Given this list of marker genes SPINK5, TRIM55, RSPRY1, CALCRL, MAP3K13, TGIF2, CDIN1, DENND4A, PLEKHA6, DYNC1I1, JPH1, FERRY3, EYA2, CREBZF, CYB5R4, R3HDM2, TRAF7, SORT1, NEDD4, HOXB2, EPHB2, RPS6KB1, APOBEC2, ZNF593, TMED10, SLC25A12, MGAT4C, CTCF, ZBTB43, TAF5, LBX1, RPL4, GAB2, PRRG4, UBR5, CAPN6 (calpain 6), PPP1R3D, UNC13B, ARL4C, RAB1A, COL7A1, HOXD10, EPHA3, STK3, IMPDH2, PNOC, CLSTN2 (NCBI Gene Id 64084), DAP3, LCOR, IRS1, PSME3, EYA1, UQCRC2, LRRTM1, SLC16A6, CACNB3, GOLGA6L9, DYNLRB2, PUM3, CDKN2B, SPRED1, FITM1, INPPL1, CDKN2C, KCNH2 (potassium voltage-gated channel subfamily H member 2), TNIP3, ST7L, ACVR1, GOLGA8A, DNAJB5 (NCBI Gene Id 25822), DCAF17, ANKS1B, SEMA7A, ADCY10, PARP16, NIPBL, APBA1, RBX1, HNF1B, GOLPH3L, ITCH, FNBP1L, IRX4, GPC4, TNFRSF19 (TNF receptor superfamily member 19), CDH10, DYSF, CEP57, ABLIM1, ABTB2, C12orf42, CTNNA3, GOLGA6L2, MXI1, EDC4, ALDOC, WDR49, MYF6, GTF2F2, SOST, DNM3, H1-0, PSME3IP1, GOLGA6A, TGFBR1, NXPH4, GPHN (gephyrin), LHX1, TGIF1, LNPK, TSHZ2, NMNAT2, TMEM125, TNS2, SELPLG, BMP1, NRGN, SESN1, NR4A3, SLC4A10, ADGRB3, ZC3H18, IKZF5, APOO, WWC1 (NCBI Gene Id 23286), PCBP4, POU3F3, NLK, UNC79, PBRM1 (NCBI Gene Id 55292), UBE3D, RAD51AP1, HOXA2, PDGFRA, CAB39, GLRA1, TUBB2B, MOSMO, ACVR2A, SCUBE3, ELAVL2, PPP3CA, IP6K3, AEBP2, SAMD1, SERPINI1, GPR156, IKZF2, CAPZA1, SKIDA1, AZIN1, OBSCN, PPP1R7, TRAF3 (NCBI Gene Id 7187), WARS1, DOP1A, PIK3R3, PPP1R12C, ADCY8, KIFBP, FRMD3, FAM76B, WNT10A (NCBI Gene Id 93651), KLHL1, SLC23A2, FAM217B, FOXO3, ANKRD13A, RFTN2, RNF14, RAMP2, GREB1L, FBXO24, HCN1, DCTN1, AHR, TNKS1BP1, HFM1, MAP1LC3B, WNT2, SPOCK2, SMDT1, METTL8 (NCBI Gene Id 79828), KCTD8, CYLD, LRCH4, STX4, HCFC2, USP15, PPP2R2B, MAP2K5, MAB21L2 (mab-21 like 2), NPPA, MAX, RNF152, ASH1L, CCN4, TBX2, CRH, CHRNB3, ZEB2, CXXC5, ANKRD12, VAMP8, ONECUT2, FOXP2, RSBN1, TUBB4A, DES, TLK2, GRIA1 (glutamate ionotropic receptor AMPA type subunit 1), DDX6, MED13, DDIT4, NHLH2, BTBD3, PASK, ESRRA, DPF3, FZD9, GOLGA2P5, TMEM109, CABP5, FKBP3, KLF14, WBP1L, RFX3, SOX4, NR3C1, LHFPL6, ANKRD35, DMC1, HIF1A, NOL4, MYL1, SLC12A2, FAM107A, ZMYND8, YY1AP1, GCAT, CHODL, GHDC, LIN28A, LPCAT3, KCNQ4, CXorf58, PCDHAC2, CA6, EN1, RESF1, FOXI1, RBM39, ACADSB, ABL2, here is a description of the gene set: Human Gene Set: TGIF_01 Genes having at least one occurrence of the motif AGCTGTCANNA in the regions spanning 4 kb centered on their transcription starting sites. This matches the TGIF transcription factor binding site V$TGIF_01 (v7.4 TRANSFAC). species: Homo sapiens